Given this list of marker genes CSNK1G2, LENG8, PICK1, RNF207, APBA1, EIF3B, ZNF580, FURIN (furin, paired basic amino acid cleaving enzyme), RBM10, NEURL4, KHDC4, KLF16, SLC12A9, ATN1, DDX11, RHBG, TLCD3B, ZBTB7B, CCAR2, RNPS1, ZNF793, SBNO2, CMTR1, TEAD3, SCUBE1, RCC1, DAGLB, CDC42EP1, HEYL, KHSRP, CLASRP, TBC1D22B, SNRNP70, KCNK5, GATAD2A, RBM14, NUP62, MCTP2, MARK2, ZNF473, SLC23A2, MOGS, DCLRE1C, PQBP1, MRPS25, RANGAP1, PRRC2A (NCBI Gene Id 7916), ZNF444, DDX39B, CACTIN, ANKRD13D (NCBI Gene Id 338692), ATAD3B, NPIPB3, GTF2H4, IL17C, SNAPC4, TCOF1, TNK2, CALR (calreticulin), TARDBP, RASSF7, LINC00115, TCF3, CFAP410, TECPR1, DPH7, KMT2D (lysine methyltransferase 2D), TRABD (TraB domain containing), HCFC1, CPSF7, SAFB2, MICALL1, RAD54L2, CCDC134, GIGYF1, FANCA (FA complementation group A), NCKAP5L, CUL7, SLC4A11, SNHG3, AMPD2, MAPK8IP3, IQCG, SH3BP1, THOC2, RBBP6, SYMPK, PHF21A, SUV39H1, TICAM1, TEPSIN, RNF214, CSNK2B, EHMT2, CRYGS, DCAF8, ANKRD13C-DT, FXR2, HAUS8, SMG7, SH3BP2, FBXL18, SUGP2, SMARCA4, CNTROB, SPPL2B, RABGAP1, MAPRE3, SETD5, POLM, DRG2, CCDC93, QTRT1, DEPDC5, CIC, NUTM2E, CTNND1, LEMD2, UPB1, SRL, MINK1, ZNF202, AP5Z1, FBXL19, FNBP4, MBD3, PTBP1, B4GALT1, INTS15, HDAC10, HPCA, ZNF611, ZNF692, MYO9B, TEAD4, TNPO3, ABCF3, FKBP1A, REXO1, NUP214, LRRC74A, GRAMD4, LSM14B, ABCC10, MSTO1, TRMU, ZNF436-AS1, SH3BP5L, ARHGAP17, MIRLET7D, HIP1R, CSNK1E, EPN1, RAP1GAP2, LMNA, UBAP2L, EVI5L, SMG9, ANKRD54, LIMK2, FOXO4, ATAT1, AGRN (NCBI Gene Id 389836), DENND5A, TRRAP, DHX33, CAMK2B, TTC17, RTKN, ZBTB5 (NCBI Gene Id 9925), LINC01355, ACAD10, ATXN2L (ataxin 2 like), SETD1A, NOTUM, TAF1C, NPM3, NFKBIL1, LINC02693, ZNF638, TLN1, SMG5, TTC13, SRRM2, DUOXA2, MAP2K2, TMEM259, PPP1R12C (protein phosphatase 1 regulatory subunit 12C), ARMC6, HNRNPU, SMARCD1, SEMA6C (semaphorin 6C), CAPN15, PPP6R2, KDM4A, GPC2, ATF5, PHF5A, SLC52A3, PPM1G, LLGL1, GLP1R, APBA3, TCHP, SEC31B, CNOT3, ACIN1, R3HDM4, CUL9, TAF15, STK11, IFRD2, MDN1, ZNF133, L3MBTL2, TBC1D22A-DT, SFSWAP, GFER, ACAP1, LTB4R, CHRNB2, ERCC2, FBXO46, PUS1, SUN1, FBRSL1, PDXP, MTOR, COPS7B, MYL10, ZDHHC24, AP5S1, ZNF316, MEF2D, XPO5, PHKG2, PTOV1-AS2 (NCBI Gene Id 101928378), DXO, RANBP3, SGSM3, SETDB1, PPRC1, BRD1, TRAF2, GRIPAP1, U2AF2, HNRNPD, IL18BP, HDAC7, RUNX3, TPM2, INTS1, DENND4B, ARPC5L, LPAR2, LINC02627, TSPAN14, NSUN4, ARHGEF11 (NCBI Gene Id 9826), ZMIZ2, CDC42SE1, UQCC2, USP21, GGA1 (golgi associated, gamma adaptin ear containing, ARF binding protein 1), EYA3 (NCBI Gene Id 2140), ARHGEF2, TYW5, PBX2, RPL18, VARS1, ZMYND19, DMWD, GRIP2, GAS5, SRCAP, NSUN5P1 (NSUN5 pseudogene 1), ZNF646, MAPK11 (NCBI Gene Id 5600), FBXO44, LIMD2 (NCBI Gene Id 80774), HIRA, ZNF358, SUPT7L (NCBI Gene Id 9913, SPT7 like, STAGA complex subunit gamma), TNPO2, SPHK2, TMEM86B (NCBI Gene Id 255043), SFTPC, CYBA, ZNF598, CC2D1B, SPON2, SEMA6B, ZNF524, RBM15B, LRCH4, PPARD, MYPOP, POLR2F, DAZAP1, UNC13D, HSF4, MIIP, MCTS1, TMEM201, URB2, ARHGAP30, GBA2, SAP25 (Sin3A associated protein 25), SEC61A2, PHPT1, BICRA, SCAF1, SRRT, SF1, ILF3, ENGASE, TMEM63A, CDK3, LARP1, PIP5K1A, SZT2, SLC39A3, KCTD13, KMT2E-AS1, DOT1L, KAT8, CYP2D6, ATAD3A, PABPN1, NEU4, ABCA7, ZC3H7B, BAZ1B, RBM33, NOL8, MTSS2, here is a description of the gene set: Genes down-regulated in non-metastatic breast cancer tumors having type 1 amplification in the 20q13 region; involves ZNF217 locus only. Human Gene Set: GINESTIER_BREAST_CANCER_ZNF217_AMPLIFIED_DN from publication Ginestier C, Cervera N, Finetti P, Esteyries S, Esterni B, Adélaïde J, Xerri L, Viens P, Jacquemier J, Charafe-Jauffret E, Chaffanet M, Birnbaum D, Bertucci F (PMID 16899599) PURPOSE: Amplification of chromosomal region 20q13 occurs in breast cancer but remains poorly characterized. EXPERIMENTAL DESIGN: To establish the frequency of 20q13 amplification and select the amplified cases to be studied, we used fluorescence in situ hybridization of bacterial artificial chromosome probes for three 20q13 loci (MYBL2, STK6, ZNF217) on sections of tissue microarrays containing 466 primary carcinoma samples. We used Affymetryx whole-genome DNA microarrays to establish the gene expression profiles of 20q13-amplified tumors and quantitative reverse transcription-PCR to validate the results. RESULTS: We found 36 (8%) 20q13-amplified samples. They were distributed in two types: type 1 tumors showed ZNF217 amplification only, whereas type 2 tumors showed amplification at two or three loci. Examination of the histoclinical features of the amplified tumors showed two strikingly opposite data. First, type 1 tumors were more frequently lymph node-negative tumors but were paradoxically associated with a poor prognosis. Second, type 2 tumors were more frequently lymph node-positive tumors but were paradoxically associated with a good prognosis. Type 1 and type 2 showed different gene expression profiles. No 20q13 gene could be associated with type 1 amplification, whereas several 20q13 genes were overexpressed in type 2 tumors. CONCLUSIONS: Our results suggest that amplified tumors of types 1 and 2 are two distinct entities resulting from two different mechanisms and associated to different prognosis. studied in species Homo sapiens